Given this list of marker genes OPN4, GNAT2, CRY1, RGR, CRY2 (cryptochrome circadian regulator 2), OPN1SW, GPR52, RHO, OPN1MW3, GPR88 (NCBI Gene Id 54112), OPN1LW, RRH, OPN1MW, ELOVL4 (ELOVL fatty acid elongase 4), OPN1MW2 (opsin 1, medium wave sensitive 2), OPN5, OPN3, here is a description of the gene set: studied in species Homo sapiens Human Gene Set: GOMF_PHOTORECEPTOR_ACTIVITY The function of absorbing and responding to incidental electromagnetic radiation, particularly visible light. The response may involve a change in conformation.